The following is a description of a gene set: Any process in which an organelle is maintained in a specific location within a cell and prevented from moving elsewhere. Mouse Gene Set: GOBP_MAINTENANCE_OF_ORGANELLE_LOCATION studied in species Mus musculus, and this is the list of marker genes: Gpsm2, Akap9, Aspm, Uvrag, Tbccd1, Arhgap21, Pafah1b1, Atp2a1, Polr2m, Spout1, Sirt1